Given this list of marker genes Ivns1abp, Trim43a, Map10, Pag1, Tfrc, Myoc (NCBI Gene Id 98481), Slc16a14, Pcsk5, Cyp2j12, Tm9sf3, Krtap13-20, Vapa, Pald1, Gatc, Insm1, Stard13, Actc1, Zfp282, Lhx8, Ugcg, Gatad2b, Pacs2, Ikbke, Mpi, Gpr137, Il1rn, Prpf39, Bhlhe41, Zfp300, Hcn3, Tmem185b, Map4k4 (mitogen-activated protein kinase kinase kinase kinase 4, NCBI Gene Id 98646), 5031439G07Rik, here is a description of the gene set: Genes predicted to be targets of miRBase v22 microRNA mmu_miR_7224_5p in miRDB v6.0 with MirTarget v4 prediction scores > 80 (high confidence targets). Mouse Gene Set: MIR_7224_5P species: Mus musculus from publication Chen Y, Wang X (PMID 31504780)